The following is a description of a gene set: species: Mus musculus Any process that activates or increases the frequency, rate or extent of voltage-gated potassium channel activity. Mouse Gene Set: GOBP_POSITIVE_REGULATION_OF_VOLTAGE_GATED_POTASSIUM_CHANNEL_ACTIVITY, and this is the list of marker genes: Lrrc38, Akap6, Lrrc55, Lrrc52, Lrrc26, Nppa, Akap7, Rnf207